The following is a description of a gene set: from publication Chessler AD, Unnikrishnan M, Bei AK, Daily JP, Burleigh BA (PMID 19201883) studied in species Homo sapiens To investigate the early host response triggered by three different strains of Trypanosoma cruzi at a local infection site, changes in host gene expression were monitored in a murine intradermal infection model using Affymetrix oligonucleotide arrays. Robust induction of IFN-stimulated genes (ISGs) was observed in excised skin 24 hours post-infection where the level of ISG induction was parasite strain-dependent with the least virulent strain triggering a muted IFN response. Infection of mice immunodepleted of IFNγ-producing cells or infection of IFNγ-deficient mice had minimal impact on the IFN response generated in T. cruzi infected mice. In contrast, infection of mice lacking the type I IFN receptor demonstrated that type I IFNs are largely responsible for the IFN response generated at the site of infection. These data highlight type I IFNs as important components of the innate immune response to T. cruzi the site of inoculation and their role in shaping the early transcriptional response to this pathogen. We used microarrays to detail the local host transcriptional response to intradermal T. cruzi infection in WT mice and mice depleted of NK cells, or deficient in IFN-gamma or type I IFN responses. Additionally we compared the local host-transcriptional response generated to infection with 3 different strains of Trypanosoma cruzi (Y, Brazil, and G). Human Gene Set: GSE13522_CTRL_VS_T_CRUZI_Y_STRAIN_INF_SKIN_BALBC_MOUSE_DN Genes down-regulated in skin from BALB/c mice after injection of: control versus Trypanosoma cruzi (strain Y)., and this is the list of marker genes: GUCY1A1, A1CF, DLX6, IGF1R, SCARNA17, CARF, TCF7, NTN4, UGCG, CNTN6, CNN3, EPHB6, TRIO, IFT80, LHX5, ST8SIA6, CD9, CRIM1, CBARP, MIR449A, ST6GAL1, RBMY1A1, FRAT2, MIR9-1, CHST15, RREB1, POU4F3, PLXDC2, ALDH2, CNKSR3, CCDC88A, DYNC2H1, MSRB2, BICDL1, ADGRL1, ADCY6, DPM3 (dolichyl-phosphate mannosyltransferase subunit 3, regulatory), STON1, SASH3, EEIG2, LINGO2, SLC12A7, MS4A4A, GABRA6, RGS9, THUMPD2, PRG4, PRKAR2B (NCBI Gene Id 5577), SCMH1, ACTN1, KLF3, FGF20, SFMBT2, UNKL, ITGA5, MATN2, MAD1L1, EVL, TTC28, RGS2, CALHM6, LEF1, LDHB, FHIP1B (FHF complex subunit HOOK interacting protein 1B), MAGI3, PHF13, TTL, SELL, MFHAS1, THEMIS, ANKRD1, MIR218-1, LMO4, CC2D2B, FAM83B, SLC44A1, HDAC9, CYP39A1, SLC25A23, LRIG1, VSTM2A, ST8SIA1, ITM2A, FOXP1, PLAG1, IL6R, DDX3Y, PDE7A, TTYH3, SYDE2, CNGA1, DGKZ, BACH2, RERE, IGF2BP3, IL2, UTY, PKD1, SQOR, MIR541, KRTAP6-3, GSX1, NXPE2, DYRK1B, ZNF318, CCNO, TNKS1BP1, MIR128-1, KRT2, KLHL22, CLCF1, IQCG, UCP1, ZFP14, CERS6, IL17A, SATB1, ZBTB10, CLEC4D, CCR7, TCF20, SPRY1, TBC1D4, DZIP1, SOX4, GPSM1, EML5 (NCBI Gene Id 161436), PARP8, PDE3B, CALCOCO1, HOXD13, TUBB2B, TCF4, GLIPR1L1, QSER1, NSG2, ADRA1B, CYRIA, PABPC4L (NCBI Gene Id 548638)